The following is a description of a gene set: Mouse Gene Set: MIR_18B_3P from publication Chen Y, Wang X (PMID 31504780) species: Mus musculus Genes predicted to be targets of miRBase v22 microRNA mmu_miR_18b_3p in miRDB v6.0 with MirTarget v4 prediction scores > 80 (high confidence targets)., and this is the list of marker genes: Ulk2, Afg2a, Mtcl2, Cwc25, Cyp1a1, Otud7b (OTU domain containing 7B), Tab2, Adgrl1, Satb1, Tmem200a, Atad1, Pip5k1a, Afdn, Rdh13, Hnf1a, Atp4a, Zfp131, Mettl8, Galnt7, Fndc3a, Sarm1, Wscd2, Cyp2c50, Atf6, Rnd3, Fli1, Ric1, Semg1 (semenogelin 1), Cd84, Nsun4, Dlg3, Flrt3, Pramel12, Spesp1, Arhgap11a